Given this list of marker genes TIMP2, RAMP2, EDN1, F2R, CCND1, CDC14A, CAV1, ARRB1, BMP4, NARS2, HCK, APLN, CXCL12, CPD, GPX1, ABCG1, TCF7L1, CNN2, AMIGO2, TUBA1B, CRYAB, MYLIP, CPE, RRAS2, ZMAT3, CCN1, ASS1, here is a description of the gene set: Genes up-regulated in SEND cells (skin endothelium) at normal oxygen (normoxia) conditions after knockdown of ELK3 by RNAi. Human Gene Set: GROSS_ELK3_TARGETS_UP The ternary complex factor Net/Elk3 is downregulated in hypoxia and participates in the induction by hypoxia of several genes, including c-fos, vascular endothelial growth factor and egr-1. However, the global role of Net in hypoxia remains to be elucidated. We have identified, in a large-scale analysis of RNA expression using microarrays, more than genes that are regulated by Net in hypoxia. In order to gain insights into the role of Net in hypoxia, we have analysed in parallel the genes regulated by HIF-1alpha, the classical factor involved in the response to hypoxia. We identified about genes that are regulated by HIF-1alpha in hypoxia. Surprisingly, when we compare the genes induced by hypoxia that require either Net or HIF-1alpha, the majority are the same (75%), suggesting that the functions of both factors are closely linked. Interestingly, in hypoxia, Net regulates the expression of several genes known to control HIF-1alpha stability, including PHD2, PHD3 and Siah2, suggesting that Net regulates the stability of HIF-1alpha. We found that inhibition of Net by RNAi leads to decreased HIF-1alpha expression at the protein level in hypoxia. These results indicate that Net participates in the transcriptional response to hypoxia by regulation of HIF-1alpha protein stability. species: Mus musculus from publication Gross C, Dubois-Pot H, Wasylyk B (PMID 17704799)